The following is a description of a gene set: studied in species Mus musculus The multiplication or reproduction of cells, resulting in the expansion of a cell population that contributes to the shaping of the heart. Mouse Gene Set: GOBP_CELL_PROLIFERATION_INVOLVED_IN_HEART_MORPHOGENESIS, and this is the list of marker genes: Tgfbr2, Ctnnb1, Eya1, Rbpj, Mks1, Pim1, Gng5, Eng, Smad4, Bmp10, Tbx5, Pitx2, Isl1, Tbx1, Notch1, Bmpr2, Hes1, Tbx3, Hand2, Sox9 (SRY (sex determining region Y)-box 9), Six1